The following is a description of a gene set: part of: Axon guidance Netrins are secreted proteins that play a crucial role in neuronal migration and in axon guidance during the development of the nervous system. To date, several Netrins have been described in mouse and humans: Netrin-1, -3/NTL2, -4/h and G-Netrins. Netrin-1 is the most studied member of the family and has been shown to play a crucial role in neuronal navigation during nervous system development mainly through its interaction with its receptors DCC and UNC5. Members of the Deleted in colorectal cancer (DCC) family- which includes DCC and Neogenin in vertebrates- mediate netrin-induced axon attraction, whereas the C. elegans UNC5 receptor and its four vertebrate homologs Unc5a-Unc5d mediate repulsion. Reactome Pathway: Netrin-1 signaling species: Homo sapiens, and this is the list of marker genes: PRKCQ, ABLIM3, NTN4, TRPC7, WASL, RGMB, RGMA, HJV, UNC5D, RAC1, FYN, SLIT1, ABLIM1, SLIT3, TRPC5, AGAP2, ROBO1, EZR, PTK2, SRC, SIAH1, UNC5B, PTPN11, ABLIM2 (actin binding LIM protein family member 2), DSCAML1, UNC5A, NTN1, TRPC4, DOCK1, UNC5C, TRPC3, PITPNA, TRPC1, CDC42, DSCAM, NEO1, PLCG1, SIAH2, TRIO (NCBI Gene Id 7204), SLIT2, MYO10, DCC, TRPC6, NCK1